The following is a description of a gene set: Human Gene Set: GSE22935_WT_VS_MYD88_KO_MACROPHAGE_12H_MBOVIS_BCG_STIM_DN Nitric oxide (NO) produced by macrophages (MØs) is toxic to both host tissues and invading pathogens and its regulation is therefore essential to suppress host cytotoxicity. MØ arginase 1 (Arg1) inhibits NO production by competing with NO synthases for arginine, the common substrate of NO synthases and arginases. Two signal transduction pathways control Arg1 expression in MØs. First, a MyD88-dependent pathway induces Arg1 in intracellular infections, while a second Stat6-dependent pathway is required for Arg1 expression in alternativelyactivated MØs. We found that mycobacteria-infected MØs produce soluble factors that induce Arg1 in an autocrine-paracrine manner via Stat3. We identify these factors as IL-6, IL-10 and GCSF. We further establish that Arg1 expression is controlled by the MyD88-dependent production of IL-6, IL-10 and G-CSF rather than cell intrinsic MyD88 signaling to Arg1. Our data reveal the MyD88-dependent pathway of Arg1induction following BCG infection requires Stat3 activation and may result in the development of an immunosuppressive niche in granulomas due to the induced Arg1 production in surrounding uninfected MØs studied in species Homo sapiens from publication Qualls JE, Neale G, Smith AM, Koo MS, DeFreitas AA, Zhang H, Kaplan G, Watowich SS, Murray PJ (PMID 20716764) Genes down-regulated in macrophages 12h after M. bovis BCG infection: wildtype versus MYD88 knockout., and this is the list of marker genes: C19orf25, UBE2D1, GDF15, LLGL1, NLRP3, GLIS2, SLC44A1, PRODH2, ISG15 (NCBI Gene Id 9636), CFAP91, RMDN3, TSPAN3, INHBA, SLFN12L, COL15A1, SLC32A1, ZCCHC3, PTGES3, CDYL, SNX18, CCDC71L, SMAD2 (SMAD family member 2), DNTTIP2, RSAD2, SPINT2, MTDH, MECR, SWAP70, PLEKHA5, ARHGEF2, FBP1, PKMYT1, IGSF6, CD82, TNNT3, ACSL4, RTN1, TMBIM6, TJP1 (NCBI Gene Id 7082), MED14, TNFAIP8L1, CDKN1C, RNF14, NUF2, BID, ZNRF1, IFIT1B (NCBI Gene Id 439996), RNF4, ADRA1B, TREX1, STARD5, CIT, C21orf91, IER3, RBMXL1, NINJ1, NCF4, PTGES, PTPN6, LCK, ACTB, PARP8, FOXQ1, TPM2, SLIT2, CCL24, BMP7, SLC30A6, PARVA, IL2RG, CXCL10, HBB, LDLR, ART3, DPEP3, PIK3CG, LCN2, CD274, SEPTIN1, KCND1, PTPN11, CHIC2, BRAF, MYB, VTA1, SLC7A11, CYP51A1, RAD51AP1 (RAD51 associated protein 1), DYNC1H1, CDC37, MMP14, PALLD, RNF19B, VASP, CSDE1, TBC1D10B, FAM133B (NCBI Gene Id 257415), BMP15, MCM10, SOWAHC, HIVEP1, TMEM63B, USP25, ABRACL, KCTD5, TMEM123, SLC28A3, LOXL2, TNFAIP3, HRH3 (histamine receptor H3), TAB2, UBE2F, SYT7, AFF1, KSR1, KIF2C, FAS, LYN, FOXN2, ABI1, HMGB2, CLIC4, DDHD1, CORIN, FAM32A, ADAM17, LCP1, PARP9, CHUK, ACTG2, CRKL, FN1, DNAJA1, TIMP1, TEX19, PHLDA1, INO80, OR7C1, ZDHHC6, APOBR, PSRC1, PTGDR2, LRRC8C, WDR1 (NCBI Gene Id 9948), PF4, SEMA4A, NFKBIZ, NAT2, RAB10, PTGS1, SGMS1, APOBEC3B, TRIP10 (thyroid hormone receptor interactor 10), FBRS, GMPPB, PPP2R2A, BTG4, OGFR, RELB, PAX7, SH3BP2, NFE2L2, SF1, HELZ2, FTCD, ISCU, KLF5, CCDC86, THOC2 (THO complex subunit 2), KPNA3, RNF41, RPS6KA4, PPP2CA, GPR84 (G protein-coupled receptor 84), LTV1, SYK, MINDY3, ASS1, MED1, RCN3, EPPK1, PSMD7, SURF4, FYB1, VASN, MYBL2, HINFP, ABHD17C, CA13, SCN3B, MPHOSPH6, SERTAD1, SH3BP4, TSKU, ADORA2B (adenosine A2b receptor), UBE2Z, DLK1, MORC3, SEC24B, PLEK